The following is a description of a gene set: Any process that results in a change in state or activity of a cell (in terms of movement, secretion, enzyme production, gene expression, etc.) as a result of a stimulus reflecting the presence, absence, or concentration of nutrients. Mouse Gene Set: GOBP_CELLULAR_RESPONSE_TO_NUTRIENT_LEVELS species: Mus musculus, and this is the list of marker genes: Ywhag, Gabarap, Ogt, Kcnb1, Gcgr, Prkag2, Txn2 (thioredoxin 2), Tbc1d7, Rraga, Cd68, Usp33, Chka, Mapkap1, Ucp2, Med1, Ep300, Wnt9b, Tcf7l2, Micu1, Usf2, Tnks, Pik3c3, Glul, Abcc8 (NCBI Gene Id 330527), Kat2b, Nupr2, Eif2ak4, Itfg2, Eif2ak3, Wdr45b, Asns, 4933438K21Rik, Atf4, Zc3h12a, Cartpt (NCBI Gene Id 27220), Postn, Gck, Nprl2, Sesn3, Mlxipl, Wipi1, Nprl3, Rragb, Xbp1, Prr5, Sh3glb1, Ifi203-ps, Rnf167, Ttc5, Ifi208, Jun, Atg14, Rxrb, Lep, Sfrp1, Impact, Dram1, Mapk1, Lpl, Gas2l1, Gdap1, Scd4, Mup1, Tnrc6a, Otud3, Lamp2, Ucn3, Col1a1, Mybbp1a, Foxa3, Fgf23, Kank2, Lrrk2, Foxo3, Rps6kb1, Atg5, Mdm2, Kdm6a, Vdr, Atg7, Prkaa2, Becn1, Ifi214, Wdr24, Gba1, Cyp27b1, Srf, Nfe2l2, Eif4g1, Csnk1a1, Prmt1, Lamtor1, Casr, Map3k5, Dap, Wrn, Mndal, Acvr2a, Yme1l1, Sp7, Wdr59, 4921509C19Rik, Xpr1, Ucn2 (urocortin 2), Inhba, Mlx, Fads1, Ywhaz, Hspa5, Kics2 (NCBI Gene Id 270802), Krt20, Higd1a, Slc38a2, Ripor1, Hfe, Pcsk9, Hmox2, Tfeb, Tsc2, Pik3c2a, Stk-ps2, Rnf152, Wdr45, Pld1 (NCBI Gene Id 99508), Pick1, Stk26, Slc38a3, Gm14151, Cyp24a1, Bmf, Sar1b, Sik2, Comt, Slco2b1, Prkag1, Gcn1, Dnajc15, Sec13, Ehmt2, Ifi206, Gpr155, Wnt4, Pak3, Snai2, Eif2s1, Eif2ak2, Rxra (retinoid X receptor alpha), Pak4, Rragc, Ctsl, Tbl2, Fes, Fnip1, Rragd, Dsc2, Tnc, Ppara, Prkab2, Plin3, Kptn, Fam107a, Ctsk, Clec16a, Ralb, Sesn2, Bcl2, Penk, Plin2, Mfsd2a, Mapk3, Wnt2b, Hrk, Ncoa1, Bmpr2, Pak1, Phex, Snw1, Ppard, Crebbp, Inhbb, Rnase4, Rictor, Trim32, Slc7a5, Atxn3, Stk24, Max, Fas, Rptor, Pik3c2b, Wipi2, Pck1, Trim24, Ifi203, Gas6, Sesn1, Angptl4, Pdia3, Alb, Pak6, Prkch, Fos, Trp53, Nuak2, Prkd1, Prkaa1, Mapk8, Atf2 (NCBI Gene Id 97033), Vps41, Srebf2, Pak5, Bhlha15, Sirt1, Castor1, Ppm1d, Tsc1, Pik3r4, Mtmr3, Ifi209, Ambra1, Depdc5, Pdk2, Flcn, Brip1, Slc2a1, Sar1a, Folr2, Klf10, Map1lc3b, Jmy, Myh13, Upp1, Smdt1, Pim1, Gabarapl2, Slc39a5, Atg4b, Myod1, Rrp8, Ifi207, Kat5, Tnfrsf11a (NCBI Gene Id 21934), Zfyve1, Map1lc3a (NCBI Gene Id 68411), Mios, Mcu, Kcnj11, Seh1l, Ifi213, Lars1, Slc34a1, Cdkn2b, Srebf1, Usf1, Prkag3, Slc39a4, Atf3, Mn1, Suv39h1, Folr1, Cpeb4, Prkab1, Becn2, Elapor1, Pak2, Bmt2, Rheb, Gabarapl1, Mtor, Cdkn1a, Ulk1, Mlst8, Cadps2, Foxo1, Mat2a, Szt2, Pdk4, Fcor, Pmaip1, Gprin3, Fbxo22